Given this list of marker genes MESD, PCDHA11, EIF4G3, PCDHA13, SSBP2, SRSF4, DLGAP4, RNF38, KDM7A, PLCXD1, PCDHA1, NAV3, SSH1, VOPP1, PCDHA3, ZNF667, TENT4B, MCAM, FXR2, EIF4B, CADPS2, TCEA1, SYT15, KRIT1, RTL5, EPPK1 (epiplakin 1), ZFHX4, TMEM245, BCL7A, ADAMTS9, PCDHAC2, CEP85L, WDR5B, OR2H1, PDE5A, TNRC6B (trinucleotide repeat containing adaptor 6B), CDK1, PHF21A, ZNF281, SLC6A19, PCDHA5, PCDHA7, GRB2, PCDHA4, ATAD2, PTDSS1, ARL4A, NRP2, C9orf72, CCNI2, DAAM1, PCDHA9, FPGT, METTL9, FSTL3, AK4, CAPZB, AP5M1, SLF2, RAI1, BLCAP, WAPL (WAPL cohesin release factor), SLC26A2, PPP1R3B, RADX, RNF139, NKD1, OTULINL, POC1B (NCBI Gene Id 91413), CSNK1G3, EIF4G1, RNF19B (ring finger protein 19B), KLF6, BMPR1B, SLC44A1, PERP, PCDHA12, CHL1, ARHGAP21, LAMTOR3, PPP2R2D, ASXL1, KHDRBS2, GABRB2, CDKN2D, PTPRJ, PCDHA10, ADGRF5, PDE3A, HIPK1, PAIP2B, USP37, RLN1, FAM184A, NRBF2, RORA, GNA12, PCDHB10, RALA (NCBI Gene Id 5898), EXOG, SOCS6, PCDHA2, PAM, ANK3, INO80D, ZBTB18, DUSP10 (NCBI Gene Id 11221), PCDHAC1 (NCBI Gene Id 94938), ZNF304, PITPNB, SMNDC1, SHB, KLHL2, PTBP2, PCDHA6, EPHA4, here is a description of the gene set: from publication Chen Y, Wang X (PMID 31504780) Human Gene Set: MIR362_3P studied in species Homo sapiens Genes predicted to be targets of miRBase v22 microRNA hsa-miR-362-3p in miRDB v6.0 with MirTarget v4 prediction scores > 80 (high confidence targets).